The following is a description of a gene set: Acetylcholine binding and downstream events species: Mus musculus Mouse Gene Set: REACTOME_ACETYLCHOLINE_BINDING_AND_DOWNSTREAM_EVENTS, and this is the list of marker genes: Chrnb3, Chrna5, Chrna1, Chrna3, Chrnb4, Chrna7, Chrna6, Chrnb2, Chrnd, Chrng, Chrna9, Chrna4, Chrne, Chrna2